The following is a description of a gene set: Any process that results in a change in state or activity of a cell or an organism (in terms of movement, secretion, enzyme production, gene expression, etc.) as a result of a lead ion stimulus. Human Gene Set: GOBP_RESPONSE_TO_LEAD_ION species: Homo sapiens, and this is the list of marker genes: PPP5C, CLDN1, PLSCR1, CAT, PPP2CA, FECH, MAP1LC3A, PPP2CB, PPP1CA, SLC34A1, BECN1, APP, MAPT (microtubule associated protein tau), ALAD, PTH, CPOX, BACE1, UCP2, DNMT3A